Given this list of marker genes PMP22, MIR3912, MYNN, CLN3, CEP192, STX4, PIGK, MAP1LC3B, CEP95, CDK8, RNASE11, FAM133B, CPSF2, PCNX4-DT, PBRM1 (NCBI Gene Id 55292), VPS13B, UNC50, PIK3R3, DHX35, FAM118B, GBA1LP, RPL3, SLFN5 (NCBI Gene Id 162394), C2orf42, PPP5C, FAM229B, SLC38A7, COMMD9 (NCBI Gene Id 399879), JRKL, COMMD8, ATP6V1G1, ABCF1, TIMM23, NR6A1, SUPT5H, BPGM, DOK1, DGAT2-DT, LRP3, ZDHHC6, LINC01605, TUBE1, HEXIM1, GPR173, WASHC5, TAF11, BET1L, AFTPH, ATG13, ABHD10, RAD52, GSDME, VTRNA1-2, FKTN, VPS33A, ARPC4, NOL6, SENP8, PLD3, NEURL2, ENSG00000270174, DGCR6L, ZBTB40 (NCBI Gene Id 9923), TSPAN4, GLOD4, DOHH, UBE2Q1, GALNS, TBC1D23, ZC3H15 (NCBI Gene Id 55854), GABARAPL1, CLEC16A, PSMB6, AFF4, PUM1, RPS27AP6, RNA5SP304, RN7SL3, ZDHHC2, RPS5, CDCA7L, SELENOW, CDC45, MAP1LC3A, WDR74, ENSG00000238142, C19orf47, TRIM7-AS2, MZF1, HM13, NDUFV2-AS1, OSGEP, ZNF292, LTA4H, FAAP100, ATP6V1C1, LINC02453, MTBP, DPH5-DT, FBXO31, PHKB, PREPL, AK5, MBD3L1, KDSR, P2RX4, PDXDC1, PRPF40A, RNU6ATAC (NCBI Gene Id 100151684), FNBP4, LINC02380, JRK, HS2ST1, CMSS1, MIR5087, MCTS1, LINC02136, RNF7 (NCBI Gene Id 9616), TOMM7, ARPC4-TTLL3, TMEM259, MYL12B, YY1AP1, DYM, METTL26, RIC8A, ZNHIT6, VWA8 (NCBI Gene Id 23078), LSM4, ZNF446, DNAI7, POLG-DT (NCBI Gene Id 119545629), CTSA, GOLM2, RNU2-2P, CCDC82, SNRPD3, DDX5, TCP11L2, SMC3, LINC01962, NTNG1, RPA2, VTRNA1-1, HDAC4-AS1, MAPK6-DT, ALDH4A1, CCDC107, FKBP15, BIRC5, UQCC6, HEXA, CDCA3, VPS11, ATP6V0D1-DT (NCBI Gene Id 101927837), DCAF8, USP5, EFHC1, KLHL12, UQCRC2, PNN, SQOR, RNF111, VCAN, NUF2, PTCD3, SNORD13, RPS3A, FAM53C, OXR1, NPTN, PARP2, TOP3A, ZNF263, LINC01556, ARL6IP6, SPPL3, MED16 (mediator complex subunit 16), WASHC2C, EIF3K, HTD2, MGME1, NDUFB1, RIMOC1 (NCBI Gene Id 285636), ZNF839, DGAT2, ZMAT2, ZZZ3, ASB7, CLTC, LINC02739, ZEB1 (zinc finger E-box binding homeobox 1), SHF (Src homology 2 domain containing F), BCYRN1, ZNF34, MPC1-DT, KIFBP, HTATSF1, MROH8, HSPA6, WRAP53, AP5Z1, ETFRF1, PARGP1, CNKSR3, IFT52, BCL6, ILF2, ZFAND5, COQ10B, TBC1D8, NUDT9, TXNDC15, CUL2, DHX35-DT, IFT122, C10orf90, MPC1, MRM3 (NCBI Gene Id 55178), ZNF507, LONP1, MBTD1, WFDC3, RGS5, DMXL1-DT, DNAJC13, PPEF1, NSMCE2, AMDHD2, STMN1, DNTTIP1 (deoxynucleotidyltransferase terminal interacting protein 1), HEXA-AS1, RNASEK, IGF2BP3, C10orf95-AS1, RNU6-2, USP9X, FRG1, USP3, ANK2, ATP6V0B, KNL1, LINC00963, HJV, CMC2, CSGALNACT2, LAMP1, CCDC43, ENSG00000272008, MRPS18A, DLAT, EMP1, CCDC184, BLOC1S1, PPP6R3, NPM1, FUS, AASDH, POLG, EIF3D, CWF19L2, MEMO1, NCOA5, DRAM2, RHOBTB3, TSEN2, RPN2, NAALADL2 (NCBI Gene Id 254827, N-acetylated alpha-linked acidic dipeptidase like 2), DNAAF3, CNOT11, MRPL13, SNX8, PHAF1, DPP9, CLU, NAGPA, NR1H2, PPP1R13L, BIRC2, CLCN7, HDAC2, PRMT5, FAHD1, MCTS2, DMAC2L, ZZEF1, RSRP1, PRDM8, COA5, ANKMY2, ITGB3BP, COA8, ANKRD12, CTNNBL1 (NCBI Gene Id 63927), SNORD43, UBE2I, MTHFR, CUEDC1, RN7SL1, PHRF1, LSG1, FNDC3A, CRLS1, WWP2, RPS29, UTP18, HAX1, POLR2J4, GLMP, GGCX, HAGH, AFF4-DT, PRMT5-DT (PRMT5 divergent transcript), METTL3, C6orf62, UVRAG, GLA, ENSG00000239137, VAMP8, CEP192-DT, RITA1, CHEK1, PAXIP1-DT, BSG, PSMA1, WBP4, GBA1, HOXB7, SMCR8 (SMCR8-C9orf72 complex subunit), FMC1, PCNX4, MRPL15, SLC35E2B, GET4, MYL12-AS1, HSPBAP1, SNX5, GOLGA7, VIM, ILF3-DT, NOCT, CENPBD2P, NEAT1, CATSPERD, FAM21EP, ZNF219, CDC37L1-DT, TXNL1, SMARCC2, PDPR2P, COX4I1, TTI2, CIZ1, CZIB, LASP1, EMC8, LUC7L2, UFD1, LOXL3, NAPA, SGTA, SNORD2, MRFAP1, HAUS8, DDX23, EFCAB7, PKN2, MFSD1, TPP1, E4F1, FAM21FP, CTNS, APEX1, MCRIP2, BRF2, FRG1-DT, WDR81, SAP30BP-AS1, HMGXB4, RNU6-1, CHERP, SELENOF, COMMD6 (NCBI Gene Id 170622), LACTB, STK35, PLOD1, ILF3, MIR4754, LINC01588, TADA3, IPO8, RNASE4, VTI1A, BASP1, ANG, ISLR2, RN7SL2, LINC03126, SLC25A37, CEPT1 (choline/ethanolamine phosphotransferase 1), SGO1-AS1, PPP6R1, TAF5, LINC00687, SLC35A5, FH (NCBI Gene Id 83748), SH3BP5L, RPS15, ATAD2, MIR4439, RPUSD4, CUTA, LEO1, RFC3, DPH5, PSMB3, UQCRH, POR, UBE3B, TAFAZZIN, TRAPPC2L, RNF24, RNU6-9, NDUFS7, CDK4 (NCBI Gene Id 92978), SLC31A1, ADNP2, ZEB1-AS1, SHPK, EEF1G, ENSG00000232995, H3C9P, NCOA7, SACM1L, RAD9A, SNX21, MORC2 (MORC family CW-type zinc finger 2), PSMF1, TAF13, APOO, CCDC97, MCM8-AS1, C4orf36, CAMKMT, DLD, HPS5, SLC44A1, MKS1, NEURL4, DDX54, ITFG1, OXR1-AS1, TRPM8, CZIB-DT, PAXBP1, PRKCE, CACUL1, KDM4C, SDHAP2, UBR1, SGO1, CSNK1D, RRAGC, MBD4, POLR3E, GADD45B, GPSM3, SOCS5, CEP290, PIP4P1, EEF2, TLN2, DSCC1, H4C8, ANAPC5 (anaphase promoting complex subunit 5), PLAA, GTPBP6, ALOXE3, METTL13, SLC25A44, HMGN4, AFTPH-DT, CLPTM1, HARBI1, MIR3677HG (NCBI Gene Id 106660606), CNIH2, HDAC2-AS2, RPS16, UTP25, SNORA21, LIMD1-AS1, LRP6, DPY30, PAXIP1, ACTMAP, IARS1, RALGAPA1, GNS, PFDN4, NEMF, CCDC174, ENSG00000227496, MRPS16 (mitochondrial ribosomal protein S16), POLR1G, PLXDC1, GNAI3, FKTN-AS1, LINC00921, GHET1, BAX (NCBI Gene Id 581), PUM3, EPCIP-AS1, RPP14, REXO4, PTDSS1, LINC01623, RNASEK-C17orf49, MRFAP1L1, EPRS1, CHCHD2P6, MRPS14, ABT1, FDFT1, TIA1, FOS, GNL3, TIGD5, CDK16, IMP4, EWSR1, NAA30, EEF1D, H2AC8, SNRPB, VWA8-AS1, VTRNA2-1, RNY3, IPO4, RRAGC-DT, COPS7A, LTBP1, TMEM260 (NCBI Gene Id 54916), ELP3 (NCBI Gene Id 55140), LINC01775, CDIPT, BSG-AS1, FLCN (NCBI Gene Id 201163), HDAC4, BZW1, RRAGB, AGBL5, DCLRE1C, RBM25, DAP3, ATG101, SPNS1, ATG3, MAPK6, ENC1, KAT5, LRRC41, ATP6V0D1, TMTC3, PSIP1, DNAJC9-AS1, MYO9A, UBXN4, SOX2-OT, FMC1-LUC7L2, GUSBP1, MVP-DT, TXLNA, CDKN1B, ENSG00000282904, RAB11A, YBX1, BZW2, ATP6V1H, MIR4521, HNRNPH2, KCTD10, FEM1B, ZNF862, HCG14, B4GAT1, TMEM50A, CEP162, KLHL21, RHBDD3, TGDS, WASHC2A, B4GAT1-DT, SPG21, DAAM1, TMEM273, TRIM47, GUSB, CYB5D2, PDPR (pyruvate dehydrogenase phosphatase regulatory subunit), DNAAF5, ZNF45, MYO9B, EIF3B, DDI2, FRAT2, NTMT1, SNRPA, PAMR1, YLPM1 (NCBI Gene Id 56252), CFAP418, RNVU1-31, G6PC3, AHDC1, TRIM41, DMXL1, SUMF1, UTP14A, DNAJC19, BACH1, BAG5, SLC36A1, CD83P1, GTF2H1, FBXO33, VPS13B-DT, MCOLN1, VTRNA1-3, RNY1, ITGA7, DVL2, DNAJC8, CYCS, MUC20-OT1, TERF1, LINS1, PLEKHG2, EED, GUCD1, CENPN, RNF34, SLC49A4, METTL15, CLPP, CCDC115, HYAL2, RNY4, RPPH1, RALBP1, POLR1A, GRN, WDR7, RPL23, MARCHF8, MVP, EIF4A2, ZNF330, RNVU1-21, MIR3124, AGBL5-AS1, CIT, CDIPTOSP, DNAJB1 (NCBI Gene Id 3337), HRCT1, AFF1, RBM39, AOPEP, ADCK1, CPED1, PDSS2, PRKCI, ALG1, TMEM127, EID2B (NCBI Gene Id 126272), TREX1, SLC35B2, RIOK2, MAP4K1, FRAT1, POLR2L, MTERF3, RNPS1, KIAA2013, RBM33-DT, RBM33, NRDE2, BCAR3, NDUFS5, AURKAIP1, CIAO3, NUP54, VPS11-DT, CLCN6, GTF3C3, here is a description of the gene set: species: Homo sapiens Human Gene Set: GUCY1B1_TARGET_GENES from publication Yevshin I, Sharipov R, Kolmykov S, Kondrakhin Y, Kolpakov F (PMID 30445619) Genes containing one or more binding sites for (GUCY1B1) in their promoter regions (TSS -1000,+100 bp) as identified by GTRD version 20.06 ChIP-seq harmonization.